Given this list of marker genes TMEM126B, SPG7, CHKB, MFF, TAFAZZIN, FDXR, FH, VCP, SFXN4, MRPS14, MYH14, CHCHD10, TARDBP, LYRM4, GYG1, SUCLG1, DNA2, SQSTM1, TBK1, HSD17B10, PET117, MGME1, SLC25A3, FUS, GGPS1 (NCBI Gene Id 9453), here is a description of the gene set: Human Gene Set: HP_ABNORMAL_MITOCHONDRIAL_MORPHOLOGY Abnormal mitochondrial morphology studied in species Homo sapiens Any structural anomaly of the mitochondria.